The following is a description of a gene set: Pathway Definition from KEGG: AngII -> AGTR1 -> NOX2 -> ROS -> NFKB -> (VCAM1,IL6,MMP2,MMP9) AngII-AT1R-NOX2 signaling pathway. Pathway ID: N01306. Pathway type: Reference. Pathway class: nt06171 SARS coronavirus 2 (SARS-CoV-2). species: Homo sapiens Human Gene Set: KEGG_MEDICUS_REFERENCE_ANGII_AT1R_NOX2_SIGNALING_PATHWAY, and this is the list of marker genes: NFKB1, AGTR1, CYBB, VCAM1, MMP2, RELA, IL6 (NCBI Gene Id 3569), MMP9